The following is a description of a gene set: Whereas DNA methylation is essential for genomic imprinting, the importance of histone methylation in the allelic expression of imprinted genes is unclear. Imprinting control regions (ICRs), however, are marked by histone H3-K9 methylation on their DNA-methylated allele. In the placenta, the paternal silencing along the Kcnq1 domain on distal chromosome 7 also correlates with the presence of H3-K9 methylation, but imprinted repression at these genes is maintained independently of DNA methylation. To explore which histone methyltransferase (HMT) could mediate the allelic H3-K9 methylation on distal chromosome 7, and at ICRs, we generated mouse conceptuses deficient for the SET domain protein G9a. We found that in the embryo and placenta, the differential DNA methylation at ICRs and imprinted genes is maintained in the absence of G9a. Accordingly, in embryos, imprinted gene expression was unchanged at the domains analyzed, in spite of a global loss of H3-K9 dimethylation (H3K9me2). In contrast, the placenta-specific imprinting of genes on distal chromosome 7 is impaired in the absence of G9a, and this correlates with reduced levels of H3K9me2 and H3K9me3. These findings provide the first evidence for the involvement of an HMT and suggest that histone methylation contributes to imprinted gene repression in the trophoblast. from publication Wagschal A, Sutherland HG, Woodfine K, Henckel A, Chebli K, Schulz R, Oakey RJ, Bickmore WA, Feil R (PMID 18039842) Genes up-regulated in placenta of mice with EHMT2 knocked out. studied in species Mus musculus Human Gene Set: WAGSCHAL_EHMT2_TARGETS_UP, and this is the list of marker genes: NXF3, KLK12, PDHA2, DAZL, MAGEA4, MPEG1, TFPI2 (NCBI Gene Id 7980), TKTL2, CFTR, GTSF1, SYCP3, CDKN1A, NPPB, MAGEA1, ASZ1, NAA11, CMTM5